The following is a description of a gene set: studied in species Homo sapiens from publication Costello P, Nicolas R, Willoughby J, Wasylyk B, Nordheim A, Treisman R (PMID 20554967) Genes down-regulated in double positive thymocytes: untreated versus stimulated by anti-CD3. Human Gene Set: GSE21546_UNSTIM_VS_ANTI_CD3_STIM_DP_THYMOCYTES_DN Removal of the transcription factor SAP1a member of the Ternary Complex Factor (TCF) group of transcription factors which in conjunction with Serum Response Factor (SRF) has been shown to have a profound effect on positive selection in the thymus. When another TCF Elk1 is knocked out in mice there is no effect on positive selection unless it is on a Sap1a KO background where the phenotype is very severe. We have stimulated isolated double positive T cells (DPs) with anti-CD3 to mimic positive selection and compared basal and stimulated transcription across the four genotypes to discover the downstream targets of Sap1a involved in positive selection., and this is the list of marker genes: RFLNB, EFTUD2, SCARB1, IPO11, DKC1, CDCA4, SYNGR4, TARBP2, GOLGA8IP, MYO19, PRPF4, OLFM1, ARHGAP19, SUV39H1, NLE1, NVL, HPS5, KNCN, RSL1D1, CFAP20DC, CHAT (NCBI Gene Id 1103), TNFRSF10B-AS1, PHF19, BCS1L, GSR, EBF3, STARD7, TLCD3A, RPS6KA6, CLN6, SLC29A1, DSCC1, UTP14A, DDX46, SNAP47, SNHG3, PFAS, SLC39A3, ACOT11, NT5C1B, SKA2, CASP3, FAM110A (family with sequence similarity 110 member A), DAND5, PWP2, GLA, DDX39A, ANAPC1, MRTO4, SNHG17, CALML4, SART3, ANP32B (NCBI Gene Id 138551), HNRNPM, SULF2, CTPS1, SCARA3, KNTC1 (NCBI Gene Id 9735), TCF7L2, NKAIN3, BLM, GLO1, RNF126, GLRX5, TIMM50, CGN, NUP88, DDN, MBNL1, CSTF3, PHTF2 (NCBI Gene Id 57832), UNC119B, TMC1, SNRNP25, PRKCA, ALG1, URB2, SGO2, TOMM40, TXNRD3, CABLES1, BRCA1, ANKLE2, WT1, HSP90AA1, SRRM1, TEX10, SNTB2, TLE2, TPX2, POLD2, CCNB2, PANK1 (pantothenate kinase 1), RMI1, WDR76, HRH3, PSRC1, PRR11, IQCH-AS1, CDC20, CISD3, GNL3, AEN, SWAP70, FAM43A, ANAPC15, NMB, NEMP1, SRSF1 (NCBI Gene Id 650453), TCHP (trichoplein keratin filament binding), GPATCH11, KIF4A, PGP, ASPM, DISP3, OMA1, NUP85, SSNA1, KIAA0586, HS3ST2, TICRR, FXN, E2F1, SLC11A2, NRM, TARBP1, TEDC2 (tubulin epsilon and delta complex 2), NRP1, MTFP1, SLC25A26, MGME1, PCOLCE2, ARPC5L, FIRRM, PPIG, ADRA2C, CDCA5, ICMT, TMEM115 (NCBI Gene Id 11070), JMJD6, RCCD1, TUBG1, TRIM59, KIF20B, PMPCA, SPAG5, TIMELESS, SP1, POP7, DDX11L2, KIF18B, MAP3K3, PUM3, RPS2P45, MAPKAPK5, SSX2IP, MID1, TMEM109, CHAF1A, ADISSP, DUS3L, SERTAD4, DDX23, TJAP1 (tight junction associated protein 1), B3GALNT2, CHEK2, SLC25A39, TLE1, CCNF, MKI67 (NCBI Gene Id 4288), SPC24, FMNL3, MMP12, PRPF3, CEP78, CYREN, H2AX (NCBI Gene Id 3014), TBC1D2B, POLR2H, DNMT1, FUS, TCF19, SLC1A5, MCM5, NDUFV1-DT, OGFOD1, NDC1, MRPL37, TXNL4B, ATG101, PPAN, CCDC59, UNG, IGLV1-44, ZC3HC1, RAD9A, PUS1, ZNF511, EZH2 (enhancer of zeste 2 polycomb repressive complex 2 subunit)